The following is a description of a gene set: species: Homo sapiens Human Gene Set: MIR15A_3P from publication Chen Y, Wang X (PMID 31504780) Genes predicted to be targets of miRBase v22 microRNA hsa-miR-15a-3p in miRDB v6.0 with MirTarget v4 prediction scores > 80 (high confidence targets)., and this is the list of marker genes: MBNL3, PALS1, GPATCH2L, STRN3, TNKS, CYP19A1, C11orf98, NPNT, ADAM12, OPRM1, CTBP2, SYCP2, BNC2, SDC2, RNF13, ACVR2B (activin A receptor type 2B), FOXD4L6, RAB21, RAB8B, CCDC141, PWWP2A, TMEM41A, TCF20, TOB1, SLC41A2, SOCS6, LARP4, CPNE8, ESYT2, RHOBTB1, CAPZB, FOXD4L3, ARMCX2, PARP16, PNRC2, ZBTB4, CPEB2, ATP10A